Given this list of marker genes ANKRD1, ARMCX3, SOS2, PTGR3, DHRS7B, ING5, DDX3X, CD207, ERBIN, ENY2, DGCR6, CNIH4, TIAM1, AKR1B10, MEX3B, CCR2, CCL17, GPR160, ECE1, MORF4L2, STX8, DMPK, PSPH, SKIC8, C1orf53, LCN2, CCDC47, VDAC3, ITGA5, CKS2, HINT1, ZPR1, TRIB1, PSTPIP1, IK, MRPL52, CINP, CSNK1G3, MBNL2, ADCY9, RNF115, CHD7, DERL1, GPD2, TIMELESS, IFT25, ROMO1, CTU2, HIC2, MBOAT1, CDKN2D, MSMO1, GALNT7, APTX (NCBI Gene Id 94135), SLC31A1, PRKD3, NDUFB9, TLE6, PRDX4, SERPINF1 (serpin family F member 1), CCT5, RWDD1, GNA15, DBR1, PSAT1, GLT8D1 (NCBI Gene Id 91870), PPP2R5A, RNF139, XAF1, SLC39A1, FKBP7, GFOD1, DPYSL2, ARAP1, KCNE3, CYP4V2, UNC119, ZCRB1, FUCA2, NAGA, LRRC3, VPS41, ABCG2, NUDT19, UBTD2, NDUFB11, SEC11C, ACCS, C15orf40, RALBP1, NDUFA5, RAB9A, CYB5A, EIF2B3, PUM3, IFT27, TM6SF1, NOP53, VKORC1, MDH1, MED20, PRKAB2, CTDSP2, SON, TOP1MT, SLC4A2, CBY2, GALK1, RHOBTB1, DDX3Y (NCBI Gene Id 8653), TOX4, GOLGB1 (NCBI Gene Id 2804), SHQ1, NSMCE2, DCUN1D1, PPP2R3C, MBTD1, HINT3 (NCBI Gene Id 135114), NLN, TTC32, MYRFL, ZNF655, TMEM234, CRYAB (NCBI Gene Id 1410), NDUFA1, PIGA, FRMD4A (NCBI Gene Id 55691), RUVBL1, EZH2, CFAP20, ARRDC4, ARHGAP5, NDUFA13, FKBP4, CHIC2, MIER1, TMCC3, RPAIN, ASCC3, SLIRP, EMC9, CKLF, OSGIN2, PDLIM7, C4orf19, DNAJC15, SNRPD2 (NCBI Gene Id 6633), G3BP2, FARP2, ANGPTL4, CHD1, MCUB, PES1, BUD31, GUSB, DCTN6, ARHGAP22, DOCK4, METTL23, DPY19L1, USP47, ZNHIT6, DPP7, MRM3, AASDHPPT, PSMD6, ADGB, AK3, SDC3, DBI, ST8SIA4, RFC4, CPNE3, ATPSCKMT, ITIH5, PIK3C2A (phosphatidylinositol-4-phosphate 3-kinase catalytic subunit type 2 alpha), ABTB2, BRWD1, MYCBP, RNF19A, TSPAN33, NDUFV1, HSPA4, FANCA, TRPV2, REV3L, NDRG1, METTL5, MTSS1, TRIP11, NIT2, NSMF, DYNC2I2, MACIR, PIGF, TEP1, STN1, SPCS1, UXT, TLE1, here is a description of the gene set: species: Homo sapiens Genes up-regulated in B16 melanoma (day 3): untreated versus adoptive transfer therapy. from publication Kerkar SP, Goldszmid RS, Muranski P, Chinnasamy D, Yu Z, Reger RN, Leonardi AJ, Morgan RA, Wang E, Marincola FM, Trinchieri G, Rosenberg SA, Restifo NP (PMID 22056381) Myeloid-derived cells comprising the tumor stroma represent a heterogeneous population of cells critical to the structure, function and growth of established cancers. We have recently found that engineering tumor-specific CD8+ T cells to secrete IL-12 (IL-12TD) can lead to striking improvements in T-cell activity against established melanomas in murine models. Surprisingly, IL-12-dependent enhancement of CD8+ T-cell anti-tumor function did not occur through direct ligation of receptors on lymphocytes or NK cells. Instead, IL-12 sensitized host bone marrow-derived tumor-stromal cells, partly through interferon-gamma, to indirectly enhance the effects of adoptively-transferred T cells. Direct presentation of antigen by tumor was not necessary, but MHC class I expression on endogenous cells was essential for IL-12 mediated anti-tumor enhancements. Upon successful treatment with IL-12TD cells, we observed the selective elimination of tumor-infiltrating CD11b+ F4/80+ macrophages, CD11b+/ClassII+/CD11c+ dendritic cells and CD11b+/Ly6C+/Ly6G- but not CD11b+/Ly6C+/Ly6G+ myeloid-derived suppressor cells within regressing lesions. These results are consistent with a model whereby IL-12 triggers the maturation of myeloid-derived cells into competent antigen cross-presenting cells. Licensed recognition of these antigens by effector T cells may in turn trigger the collapse of the tumor stroma and aid in the regression of large vascularized lesions. Human Gene Set: GSE29164_UNTREATED_VS_CD8_TCELL_TREATED_MELANOMA_DAY3_UP